The following is a description of a gene set: Binding to a protein upon poly-ubiquitination formed by linkages between lysine residues at position 48 in the target protein. studied in species Homo sapiens Human Gene Set: GOMF_K48_LINKED_POLYUBIQUITIN_MODIFICATION_DEPENDENT_PROTEIN_BINDING, and this is the list of marker genes: VCP, ZFAND2B, MINDY1, IKBKE, UBQLN4, RNF31, UFD1, UBXN1, NPLOC4, MINDY2